Given this list of marker genes Kcnk2, Cited2, Phb2, Rora, Tmbim6, Lmna, Rgcc, Aqp3, Stc1, Hyou1 (NCBI Gene Id 58204), Ndrg1, Slc9a1, Prkaa1, B3gat1, Tert, Kcnk3, Higd1a, Slc8a3, Trem2, Ddr2, Gad2, Cbl, Vasn, Inhba, Angpt4, Edn1, Ndnf (neuron-derived neurotrophic factor), Egln1, Hp1bp3, Ucn3, Bad, Twist1, Atf2, Dnm1l, Eno1, Slc29a1, Nono, Ptgis, Ogt, Nol3, Sirt2, Hif3a, Bmyc, Foxo3, Pck1, Bbc3, Pik3cb, Rtn4, Mir214, Commd1, Tigar, Pten, Cbs, Usp19, Chchd2, Stc2, Adam8, Src, Pdk3 (pyruvate dehydrogenase kinase, isoenzyme 3), Nkx3-1, Ubqln1, Bnip3, Egln2, Nop53, Cysltr2, Ngb, Ajuba, Pdk1 (NCBI Gene Id 78869), Sirt4, Akt1, Cr1l, Ptprd, Mir874, Bnip3l, Notch1, Stat3, Gngt1, Ado, Mief1, Cpeb2, Tbl2, Eif4ebp1, Zfp36l1, Cybb, Oprd1, Pgk1, Hilpda, Kdm6a, Ndp, Vhl, Egln3, Gata6, Eno1b (NCBI Gene Id 433182), Rptor, Myc, Ep300, Mtor, Vegfa, Adrb2, Acaa2, Fabp1, Epha4, Cdkn1b, Fos, Pparg, Aqp1, Casr, Drd1, Mgarp, Epas1, Slc2a4, Brip1, Mstn, Ccna2, Mir199a-2, Gnb1, Fndc1, Ptgs2, Zfas1 (NCBI Gene Id 68949), Egr1, Pink1, Prkce, Kcnd2, Rwdd3, Ak4, Ddah1, Chchd2-ps, Rock2, Npepps, Mdm2, Suv39h1, Clca1, Trp53, Ireb2, Bcl2, Tgfb1, Fam162a, Ptpn1, Sfrp1, Aifm1, Dnmt3a, Sirt1, Suv39h2, Mir668, Mlst8, Drd2, Vldlr, Mst1, Sdhd, Ero1a, Ppard, Hif1a, Scn2a, Nfe2l2, Cpeb1 (NCBI Gene Id 12877), Fmn2, Daxx, P4hb, Map2k1, Cysltr1, Endog, Atf4, here is a description of the gene set: Any process that results in a change in state or activity of a cell (in terms of movement, secretion, enzyme production, gene expression, etc.) as a result of a stimulus indicating lowered oxygen tension. Hypoxia, defined as a decline in O2 levels below normoxic levels of 20.8 - 20.95%, results in metabolic adaptation at both the cellular and organismal level. Mouse Gene Set: GOBP_CELLULAR_RESPONSE_TO_HYPOXIA studied in species Mus musculus